Given this list of marker genes FKBP6, METTL21A, ITGB2, PTGES3L, HSPA1A, DNAJB2, PDXP, CYP1A1, CYP2E1, HSPA14, PRKD1, APAF1, MVD, CSNK2A1, METTL18, HDAC6, PPID, NOD2, BAG6, FAF1, HSPA1B, BAK1, AHSA1, HSPA2, SLC12A2, DNAJC18 (DnaJ heat shock protein family (Hsp40) member C18), GPR37, NUP62, EEF1AKMT3, HIF1A, CREB1, BAG2, HDAC2, ITGAM, NR3C1, DNAJB6, PTGES3, CDK5, TELO2, TFRC, HSPA9, APOA2, TOMM34, USP19, FKBP4, BMAL1, TSC1, OGDH, RPS3, ERN1, MAPT, STUB1, BCOR, IRAK1, SACS, CDC37, ADORA1, DNAJA1, AHR, STAU2, PGLYRP1, CHORDC1, DAXX, STIP1, LIMK1, APOA1, CDK1, DNAJB9, FKBP5, GMEB1, FICD, KPNB1, EIF2AK3, DNAJB7, DNAJC2, ZFP36, DNAJB14, DNAJB12, LMAN2, DNAJB1, DNAJC10 (NCBI Gene Id 54431), METTL21C, HSPA7, TPR, HSPA1L, PPP5C, CDC37L1, EEF1D, TFAM (transcription factor A, mitochondrial), KDR, HTT, SNCA, HSPA5, HIKESHI, PPEF2, GBP1 (NCBI Gene Id 2633), UNC45B, PACRG, IQCG, HDAC8, SPN, RNF207, PRKN, SGTB, DNAJC8, METTL23, METTL22, HSPA13, DNAJA4, TTC4, SSUH2, DNAJB3, UNC45A, ST13, DNAJC9, TSC2, BAX, DNAJC7, DNAJC6, HSPA8, CAMKMT, DNAJA2, GUCY1B1, DNAJB8, HSPA6, HSF1, HSP90AB1, NPAS2, DNAJA3, ETFBKMT, here is a description of the gene set: Binding to a heat shock protein, a protein synthesized or activated in response to heat shock. studied in species Homo sapiens Human Gene Set: GOMF_HEAT_SHOCK_PROTEIN_BINDING